The following is a description of a gene set: Genes down-regulated in CD4 T cells over-expressing FOXP3 and PPARg1 isoform of PPARG: GW1929 versus rosiglitazone. Human Gene Set: GSE37534_GW1929_VS_ROSIGLITAZONE_TREATED_CD4_TCELL_PPARG1_FOXP3_TRANSDUCED_DN from publication Cipolletta D, Feuerer M, Li A, Kamei N, Lee J, Shoelson SE, Benoist C, Mathis D (PMID 22722857) species: Homo sapiens Pioglitazone treatment of CD4+FoxP3- T cells transduced with Pparg and Foxp3 up-regulated a set of genes whose products have been implicated in lipid metabolism pathways. To verify the specificity of this treatment, we performed microarray analysis on Foxp3+Pparg1-transduced CD4+FoxP3- T cells after treatment with other PPARg agonists such as Rosiglitazone (TZD) and GW1929 (non-TZD)., and this is the list of marker genes: FAM53C, CNOT6, FAM193A, ARHGAP26, TUBGCP6, AKAP9 (A-kinase anchoring protein 9), BRWD1, DRG1, EIF5, NEK1, GPNMB, SLC12A7, PCF11, CUEDC1, PTGR2, SLC25A24 (NCBI Gene Id 92093), FBXO28, NCL (NCBI Gene Id 4691), HOOK3, RFLNB, GBP4, SARAF, RFX3, RAVER1, ZFP82, GTF2IRD2, PHETA2, GSTK1, RAB6A, MED24, MIR142, SOAT2, RBBP9, MFHAS1, SAP18, RORA, RIPOR1, UBXN11, FANCM, TMEM41A (transmembrane protein 41A), SLC37A3, TOE1, RER1, SMARCA2, SCLY, NAA60, MAMDC2, CPSF1, QRICH1, FBXO9, WDR83, PCM1, CRADD, BSPRY, WWOX, PIGK, PBXIP1, PPP1R9B, MAP3K2, TADA1, ARL4A, TMEM63A, SULF2, SLC35C1, CDK18, CABLES1, ATP13A3, WDR26, MIR362, ZHX2, UROD, MPP7, IFIT3, NAA15, PSMD13, NTAQ1 (NCBI Gene Id 55093), TNKS1BP1, PIAS2, ITGB3, WDR70, ATPAF1, SPIN1, PSTK, CYTH2, SLC2A10, BBS9, PTPDC1, RAP2A, XK, RNF169, GPBP1L1, ITM2A, MYH9, SLC25A16, PAIP2, RICTOR, CALCRL, PCBP4, WDCP, TMBIM4, KAT7, PIGX, KIZ, MOCS2, EPSTI1 (epithelial stromal interaction 1), PPP1R37, PYCARD, MMP9, ELMOD2, RNGTT, NPRL2 (NPR2 like, GATOR1 complex subunit), DYRK1B, CTDSP1, CCDC28A, VPS54, PTPN2, QSOX1, GYG1, SRD5A3, EGLN3, SP2 (Sp2 transcription factor), RAB3GAP2, PDS5A, UBE2R2, RAB4A, LSM1, FEZ2 (NCBI Gene Id 9637), ANKRD17, ARB2A (ARB2 cotranscriptional regulator A), FCHO2, SGK1, TEX261, MBD1, CBY1 (chibby 1, beta catenin antagonist), MAT2B, STAM, MT-CO1 (NCBI Gene Id 4512), ABCB7, SPEN, TCOF1, PIAS3, MCM3AP (minichromosome maintenance complex component 3 associated protein), AGO2, TET1, SCYL3, APOBEC1, ZCCHC17, ARMC2, ZMAT5, DAD1, CABLES2, AVIL (advillin), BMP7, MTCP1, SLC44A5, ATP1B2, IPO8, EXOC6, CH25H, SLC30A6, SNX33, AUH, PI4KA, PRKDC